Given this list of marker genes ERC2, ATP2B3, CACNB2, OSBPL2, NPY, CALB2, TSPOAP1, SV2B, ADORA1, CALB1, P2RY1, CNR1, P2RX1, CACNB4, here is a description of the gene set: species: Homo sapiens Human Gene Set: GOBP_REGULATION_OF_PRESYNAPTIC_CYTOSOLIC_CALCIUM_ION_CONCENTRATION Any process that regulates the concentration of calcium in the presynaptic cytosol.